Given this list of marker genes Cyp3a41b, Ephx2, Cyp2d22, Cyp3a57, Cyp3a25, Cyp3a16, Cyp2e1, Cyp1a2, Cyp3a13, Cyp2c66, Cyp2c65, Cyp3a41a, Cyp3a44, Cyp3a11, here is a description of the gene set: electronically inferred by orthology from the curated human pathway This event has been computationally inferred from an event that has been demonstrated in another species.<p>The inference is based on the homology mapping from PANTHER. Briefly, reactions for which all involved PhysicalEntities (in input, output and catalyst) have a mapped orthologue/paralogue (for complexes at least 75% of components must have a mapping) are inferred to the other species. part of: Biosynthesis of DHA-derived SPMs Reactome Pathway: Biosynthesis of maresins species: Mus musculus